The following is a description of a gene set: Genes down-regulated in NK cells: RAG2 knockout versus RAG2 and ETS1 knockout. from publication Ramirez K, Chandler KJ, Spaulding C, Zandi S, Sigvardsson M, Graves BJ, Kee BL (PMID 22608498) studied in species Homo sapiens Human Gene Set: GSE37301_RAG2_KO_VS_RAG2_AND_ETS1_KO_NK_CELL_DN Expression profiling of Rag2-deficient Ets1++ and Rag2-deficient Ets1-- mature NK cells and WT bone marrow progenitors, WT T cells, and WT Pro B cells, and this is the list of marker genes: SAP18, HYAL2, PPARA, TOR1AIP2, SEC14L2 (NCBI Gene Id 85372), CYB5B (NCBI Gene Id 80777), GNA12, GLE1, CSNK2A1, PAQR7, RAB3D, CDC7, PIM1, GABRA6, KRT13, ABCB4, STARD7, LGALS4, CCL17, FBXO21, CD59, CYTH3, TPGS2, MAP2K2, LACTB2, TLL1, APIP, DPP4, SLC25A20, PTK2B, MFSD4A, SLC25A39, CDC42EP4, VAPB, GLB1, DNAJA2, TBCEL, ACADS, HMGA2, COL13A1, RNH1, HADH, IFNGR2, MAPKAPK5, KCNA3, KCNJ3, EIF1, ABCB10, PDCD2L, CSNK2B, DSC2, GOT1, EEA1, CSTF1, WDTC1 (WD and tetratricopeptide repeats 1), HADHB, INTS6, BIRC2 (baculoviral IAP repeat containing 2), MYL11, C19orf53, ENTPD5, CLN8, SELENBP1, GRINA, PPP1R17, FGF17, CCDC88A, NECAP1, PTGFR, DHRS7, CMTR1, GTF2B, WAC, METTL8, ULK2, PRKACA, SLC27A5, C2CD2, TMEM205, IL15RA, PPM1A, WBP1, GHITM, CCN1, MRAS, NAP1L2, ME1, SPAST, BOLA3, TNNC1, MFN1, HSDL2, ZC3H14, EIF5, MAOA, FMR1NB, UCK1, GRSF1, CHPT1, ZW10, PSCA, RNASE3, FABP1, NR0B2, CYP1A2, NELFCD, TTC7B, BRI3, UBAP1, DDX41, SUMO2P7, GPHN, KCTD20, KRTAP12-2, SNAPC2, TXNRD3, CALML4, NEXMIF, NPC1, CPT2, C5orf15, COASY, DCT, GRPEL2, TRIP13, AQP4 (NCBI Gene Id 50660), PDK1, KIF3C, TSFM, SLC2A2, SUDS3, ADIPOQ, PCMT1, AQP8, NR1H4, TRDMT1, LONP2, PRR5, ZNF598, ESYT3, GABRA1 (NCBI Gene Id 2554), GPD2, NR1I3, MMP15, INCA1, D2HGDH, DDHD2, STARD10, PPIG, COX5A, MRPL14 (NCBI Gene Id 64928), ACAA1, MINDY1, EPOR, TSPAN6, CNOT2, NDUFB3, RCE1, RAB34, INTS9, PRDX5, SLC30A1, PGRMC2 (progesterone receptor membrane component 2), ABCD3, MTSS2, PPT2, EEF1B2, PTBP2, SLC23A2, RETSAT, FANCG, IL2RA, STX8, WNT5B, NTRK3, ACE2, SMIM20, MKI67, ELMOD3, RPA1, RTF2, PDRG1, ECI1, TMEM68, ARMC10, WWC1, LYPLA1, FAM3C, TMEM245, CELF2, CASC3, AKAP8L, PRUNE1, DLG3, NDRG3, CIB2, ACSM2A, INHBE, SAR1B, PGD